The following is a description of a gene set: studied in species Mus musculus Mouse Gene Set: REACTOME_TRANSLESION_SYNTHESIS_BY_POLH Translesion Synthesis by POLH, and this is the list of marker genes: Rfc4, Rchy1, Uba52, Rfc2, Rfc1, Uba52rt, Rfc5 (replication factor C (activator 1) 5), Rpa3, Pcna, Rfc3, Sprtn, Ufd1, Nploc4, Polh, Vcp, Ubc, Rps27a (NCBI Gene Id 78294), Rpa2 (NCBI Gene Id 99984), Ubb, Rpa1